Given this list of marker genes NFATC2, FOS, JUND, JUNB, FOSL2, JUN, here is a description of the gene set: Human Gene Set: GOCC_TRANSCRIPTION_FACTOR_AP_1_COMPLEX species: Homo sapiens A heterodimeric transcription factor complex composed of proteins from the c-Fos, c-Jun, activating transcription factor (ATF) or JDP families. The subunits contain a basic leucine zipper (bZIP) domain that is essential for dimerization and DNA binding. Jun-Fos heterodimers bind preferentially to a heptamer consensus sequence (TPA responsive element (TRE)), whereas Jun-ATF dimers bind the cyclic AMP responsive element (CRE) to regulate transcription of target genes.